The following is a description of a gene set: Mouse Gene Set: GOMF_SEMAPHORIN_RECEPTOR_BINDING Binding to a semaphorin receptor. studied in species Mus musculus, and this is the list of marker genes: Sema3d, Sema3a, Sema3g, Sema4a, Sema4c, Sema3b, Sema7a, Sema3e, Sema6c, Sema6d, Sema5b (NCBI Gene Id 20357), Sema5a, Sema3f, Sema4f, Sema4b, Sema3c, Trem2, Sema6b, Sh3bp1, Sema6a, Sema4d, Rit2, Sema4g